The following is a description of a gene set: studied in species Homo sapiens Human Gene Set: MIR4276 from publication Chen Y, Wang X (PMID 31504780) Genes predicted to be targets of miRBase v22 microRNA hsa-miR-4276 in miRDB v6.0 with MirTarget v4 prediction scores > 80 (high confidence targets)., and this is the list of marker genes: MAF, CLCN5, TRIM2, TMEM218, DNAAF10, RLN1, CAMSAP2, CDKN1B, CHCHD4 (coiled-coil-helix-coiled-coil-helix domain containing 4), RIF1 (replication timing regulatory factor 1), SESTD1, CSGALNACT2, MUC15, CBLB, TRNT1, FLACC1, CANX (NCBI Gene Id 821), ZNF236, CAND1, CLDN1, B4GALT5, EPB41L1, FABP7, PCDH20, SOWAHC, RGL1, PTCD2, COA5, ZNF396 (zinc finger protein 396), MPO, ZNF461, AMOT, UHRF1, GTF2H1, ORC5, SGK3, TRIP11, GPM6B, CDC14A, BAG2, ITGB8, ITGB6, WWTR1, TBX3 (T-box transcription factor 3), MCM10, BTBD3, CALB1, ITGB1BP1, BIRC6, WIPF3, WDR37, MIS18BP1, CCDC169-SOHLH2, ANK3, ACSL1, TBL1XR1, OSBPL11, PRDM11, MRPS18A, AKT3, SENP6, NCKAP1, C11orf87, MPEG1, KIAA0930, USP44, CYRIA, POLR2J (NCBI Gene Id 5439), RLN2, TACR1, LZTR1, GAB1, KCNMB3, PALM2AKAP2 (NCBI Gene Id 5561), JMY, PPP1R3B, L3MBTL4, EIF2S1, QKI, TMEM236, RRAGC, ADAMTS6, SORL1, MINPP1, GRM5, LRP2, PHYHIPL, TP53AIP1, ZEB2, ZNF445, SETDB2, TMOD2, SH2B3, SUZ12, AFAP1L1, GABRA4, ANKRD40, ZDHHC7, SVIP, MTCL3, ALKBH8, ATP8B4 (NCBI Gene Id 79895), MEOX2, STXBP5, MEST, MALRD1, CHGB, STK38L (serine/threonine kinase 38 like), ORC4 (origin recognition complex subunit 4), ZNF451, C4orf19, PAPPA2, LRRC7, TLR5, ITSN2, RBIS, SBF2, TPR, GJB4, TRPM3, RETREG3, CLEC12B, TNKS2, GPC5, MCCC2, ATXN10, CSF2RB, ARHGAP8, NBEA, GADD45A (growth arrest and DNA damage inducible alpha), TSPAN12, AFDN, TENT4B, EXOC8 (NCBI Gene Id 149371), CEP41, ATP6AP2, SNX11, MAP3K21, RORA, SLC15A4, PCDH7, TRHDE, EYA4, SNAP91, TRIM23, SELENOI, EPAS1, TMEM170A, MTX2, FERMT2, BCL7B, GATA3, TEAD1, PBX1, RB1, MXD1, CDYL, SDC2, E2F5, TGFBRAP1, TMTC2, TBC1D12, PTPRO, TET2, VPS37A, SOHLH2, GTF2E1, ABCB7, AP5M1, TBC1D23, ASPH, HS3ST1, C1GALT1, EMC7, RRAS2, ARHGAP6, LONRF3 (LON peptidase N-terminal domain and ring finger 3), ERBB3, PLPP4, TMEM209, CDCA7, KRTAP4-9, ALDH1A3, DENND2C, SIK2, AASDHPPT, PLXDC2, PIAS2, HIRIP3, RICTOR, RPS6KA3 (NCBI Gene Id 6197), RAD1, KPNA1, TSC22D1, UBE2D3, NAP1L3, ALS2, IFNAR1, SPIN3, FXR1, AMBN, CNTN4 (NCBI Gene Id 53943), ADGRF1, RC3H1, FMR1, KRT28, GK, APPL1, HECA, ABCC12, ELAPOR2, CDH17, ZNF618, ARMC1, PDE9A, MYNN, NR1D2, SLC38A1, C3orf52, ZFYVE26 (NCBI Gene Id 338378), PLAG1, KRTAP4-7, CHUK, ST3GAL1, DNALI1, CYP26B1, TANC2, SQOR, B3GALNT1, PLCXD2 (phosphatidylinositol specific phospholipase C X domain containing 2), USPL1, FLRT2, KCNIP4, RGS7, SMIM12 (NCBI Gene Id 113444), MACIR, C8orf44-SGK3 (NCBI Gene Id 100533105), HS6ST2 (heparan sulfate 6-O-sulfotransferase 2), RASGEF1B, IL1B, DGKH, NAB1, CTDSPL2, GRAMD4, CDK19, DNAAF9, PRSS16 (serine protease 16), KMO, CHMP2B (charged multivesicular body protein 2B), SOX5, TOMM20, MTMR12, WWC3, INPP5B, TIMM8A, PACSIN2, KIAA0232, ZNF250, FAM3C, ZBTB43 (zinc finger and BTB domain containing 43), CBX1, TCP10L2, HECW2, UPB1, SSX3, PRKAA1, ASAP1, ADAM10, FAM107B, GPAM, VENTX, LSM14A, EOGT, TLCD2, SEC61A2